Given this list of marker genes BBS12, SCYL3, RBFOX1, PTEN (NCBI Gene Id 8037), IL31, VDAC2, MRPS27 (NCBI Gene Id 64948), IGF2BP2, PCDH11X, SGSM2, SPTY2D1, IFNK, NREP, TPBG (NCBI Gene Id 7162), HOATZ, DPYSL2, DNAJC10, HTR2C, MAN2B2, TOX3 (TOX high mobility group box family member 3), TNNI3K, PGM3, USP14, NFIB, EYA3, ZNF335, USP30, ST8SIA2, SOX4, NSF, ATXN7L3, HIPK3, here is a description of the gene set: Genes predicted to be targets of miRBase v22 microRNA hsa-miR-596 in miRDB v6.0 with MirTarget v4 prediction scores > 80 (high confidence targets). species: Homo sapiens from publication Chen Y, Wang X (PMID 31504780) Human Gene Set: MIR596